The following is a description of a gene set: species: Mus musculus The binding by a cell-adhesion protein on the cell surface to an extracellular matrix component, to mediate adhesion of the cell to another cell. Mouse Gene Set: GOMF_CELL_CELL_ADHESION_MEDIATOR_ACTIVITY, and this is the list of marker genes: Emb, Bsg, Nfasc, Cntn5, Dscam, Lrrc4c, Izumo1, Jam3, Cdh5, Cntn6, Epcam, Cd200, Cntn1, Igsf9, Cd200l1, Tmigd1, Cxadr, Ntng1, Mypn, Gldn, Myot, Esam, Nptn, Ppp1ca, Cd200l2, Cd200r1, Ctnnd1, Sirpa, Plxnb3, Clstn3, Ninj1, Dscaml1, Cntn2, Nrcam, Nexn, Cdh9, Cd47, Prtg